Given this list of marker genes MAP2K4, NR3C1, EHMT2, HOXB13, MDM2, GATA2, ZMIZ2, SMARCA2, HDAC7, DNAJA1, SIRT1, RACK1, KAT5, SENP1 (SUMO specific peptidase 1), SMARCC1, HDAC1, MAPK8, RXRB, NR2C1 (NCBI Gene Id 7181), EP300, TMPRSS2, NCOA1, RXRG, FOXO1, MAPK14, KAT7, GSK3B, AR, TRIM24, SPDEF, KLK3, SRY, RXRA, PKN1, NCOA2, CREBBP, KAT2B, POU2F1, REL, CEBPA, NR0B1, KLK2, MAP2K6, EGR1, SRC, HSP90AA1, CARM1, PDE9A, RCHY1, APPBP2, JUN, SMARCE1, NR2C2, here is a description of the gene set: from publication Schaefer CF, Anthony K, Krupa S, Buchoff J, Day M, Hannay T, Buetow KH (PMID 18832364) Regulation of Androgen receptor activity species: Homo sapiens Human Gene Set: PID_AR_TF_PATHWAY